Given this list of marker genes Pawr, Nupr1, Foxp3, Atf2, Septin4, Dpt, Rgn, Cebpa, Grem1, Ccr5, Ccl12, Fas, Krit1 (NCBI Gene Id 79264), Eif2ak1, Lilrb4a, Cdc73, Vsig4, Agtr2, B4galt7, Ift52, Fbxo4, Ereg, Trp53inp1, Mmp9, Il12a, Tns2, Cdkn2c, Vsir, Pdcd10, H19, Fgf2, Ski, Axin2, Tgfbr3, Tescl, Jak2, Sod2, Mtss1, F2r, Tyrobp, Tent5b, Trib1, Apc, Plk5, Ceacam1, Tnf, Pde5a, Ptprj, Bche, Fnip1, Rc3h1, Ptges, P3h3, Tgfb1, Trim35, Pdcd1lg2, Shh, Spin4, Raf1, Magi2, Pax6, Hspg2, Rara (NCBI Gene Id 19401), Serpine2, Jun, Hspa1a, Cd300a, Prnp, Apoh, Pak1, S2bpcox16, Kiss1r, Ang, Pten, Tial1, Shoc2, Trem2, Ing4, Dll1, Bnipl, Stk4, Inhba, Mtbp, Zbtb16, Tgif1, Clec4g, Lgals9, Cdk6, Ceacam2, Sh2b3, Runx3, Kcnk2, Msx2, Aqp11, Sox9, Rxra, Smad6, Il2ra, Il1a, Slurp1, Mn1, Adcyap1, Socs1, Tmigd3, Cacnb4, Atg13, Notch1 (NCBI Gene Id 68125), Tbx5, Tafa5, Arg1, Sox11, Wdr6, Cend1, Slfn1, Cblb, Bak1, Stat1, Tert, Cpb2, Cnn1, Myod1, Enpp3, Atf5, Wnt10b, Cdh1, Fezf1, Vgll4, Bax, Ptgs2, Thbs1, Csf1r, Brca2, Bmpr1b, Msx1, Xdh, Adipoq, Tsg101, Dis3l2, Gata2, Insm1, Bap1, Adarb1, Tpm1, Il1rl1, Cldn3, Dnajb2, Trp53, Cops8, Irf6, Rbp4, Rbm10, Cherp, Smad3, Dlk1, Bdnf, Sfrp2, Appl2, Clmn, Med1, H2-T23, Nox4, Ift74, Ctnnb1, Zfp503, Gna12, Glmn, Nr2f2, Myc, Cldn19, Slc16a2, Tgfb2, Apln, Dicer1, Klf9, Gpnmb, Sfrp1, Pmp22, Ripor2, Ascl2, Mir219a-1, Wdr13, Eaf2, Muc16 (mucin 16), Nppc, Sirt6, Esr1, Smarcb1, Timp3, Cdkn2b, Ift88, Kdm2b (lysine (K)-specific demethylase 2B), Il1b, Nodal, Gstp1 (NCBI Gene Id 14870), Pth1r, Synj2bp, Bcl2, Ifi35, Tfap2b, Spry2, Tmem131l, Cpeb1, Gjb6, Fzd5, C1ql4 (NCBI Gene Id 239659), Gli3, Prkg1, Nf2, Itga1, Pkp2, Vash1, Cd24a (NCBI Gene Id 12484), Mstn, Nos1, Ifitm1, Wnt11, Cited2, Srf (NCBI Gene Id 224821), Ndrg4, Nfatc1, Mir1a-2, Pdx1 (NCBI Gene Id 18609), Spry1, Gnrhr, Bmp4, Ift80, Foxa3, Fktn, Lgals3, Tmem127, Csk, Flt1, Gdf5, Sh3bp4 (NCBI Gene Id 98686), Mir219a-2, Ctla4, Bdkrb2, Scin, Lmna, Inppl1, Ngfr, Cd80, Dlc1 (deleted in liver cancer 1), Gper1, Bmp5, Nkx2-9, Kcnn4, Gabbr1, Cd9, Itgb1, Prl, Ppp2r5c, Pde9a, Ephb1, Alox8, Crtam, Gsdme, Niban2, Insl3, Ptgir, Smad2, Prox1, Esr2, Adora3, Tff1, Zbtb49, Mef2c, Aldh1a2, Sox7, Nrk, Phf7, Rapgef1, Ddr1, Pla2g2f, Cdh5, Tlr2, Ang6, Prkar1a, Eppk1, Tsc1, Ndfip1, Med31, Ptprf, Ifi30, Srpx, Krt4 (keratin 4), Btg2 (BTG anti-proliferation factor 2), Smad7, Sparc, Cysltr2, Tmem196, Apoe, Ctcf, Npm1, Fcgr2b, Strn, Comt, Arid2, Rarb, Mmrn2, Hdac2, Adora1, Wnk2, Bcl6, Bmp7, Agtpbp1, Tgfbr2, Fxyd2, Podn, Dusp10, Erbb4, Flt3, Ackr3, Dab2, Il15, Enpp7, Pmaip1, Ager, Fnip2 (NCBI Gene Id 329679), Cd44, Hdac4, Etv4, Erbb2, Atraid, Ptpn2, Rb1, Bcl11b, Cd276, Maged1, St18, Timp2, Npr3, Zfas1, H2-M3, Vax1, Atp5f1a, Hmga1b, Myocd, Cers2, Nf1 (neurofibromin 1), Etv3, Eng, Col4a3, Nfib, Bmpr2, Kank2, Bmyc, Ifng, Ccn6, Tnfrsf14, Tfap2a, Ar, Ovol2, Lzts2, Nmi, Cxcl12, Wt1, Ppargc1a, Myog, Mcc, Foxo4, Ift122 (intraflagellar transport 122), Wnt9a, Tesl1, Ifit3b, Mfn2, Phb2, Slc4a2, Emd, Ifit3, Ahr, Lefty1, Map2k1, Cdkn2a (cyclin dependent kinase inhibitor 2A), Tnfrsf9, Spn, Phox2b, Kmt2a, S1pr2, Gpld1, Lbx1 (ladybird homeobox 1), Akirin1, Ifnb1, Rhoa, Ulk1, H2ac13, Rassf5 (Ras association (RalGDS/AF-6) domain family member 5), Gna13, Ptgdr2, Slc6a4, Stk11, Cav1, Fntb, Rap1gap, Hnf4a, Ift172, Fuz, Pdcd5-ps, Nos3, Isl1, Cask, Kctd11, Dsc1, Lta, Klf13, Rarg, Zeb1, Vip, Tesc, Tes, Smarca2, Nacc2, Tarm1, Ptch1, Ang4, Kiss1, Tnfrsf21, Vtcn1, Taf6, Ang2, Btn2a2, Tpbg, Tspo, Atm, Abcc8, Slfn2, Nfe2, Pdcd4, Smyd2, Men1, Smo, Irgm1, Ccn3, Nppb, Gja1, Ptprv, Mad1l1, Nell1, Sult2b1, Sfn, Pex2 (NCBI Gene Id 52109), Wwc2, Nog, Gnrh1, Marveld3, Sf1, Hpn, Ogn, Twist2, Eif2ak2, Zbtb7b, Gas1, Wfdc1, Il12b, Spint2, Gal, Itgb1bp1, Xcl1, Igfbp5, Sox10, Ilk, Fbxo2, Tbrg1, Itch, Rerg, Ptpru, Avpr2, Ghrl, Casp3, B2m, Vipr2, Robo1, Il24, Tnmd, Tfap4, Slit2, Stat3, Lrp6, Fth1 (NCBI Gene Id 14319), Smad4, Trim32, E2f7, Dlg5, Runx1, Laptm5, Ifna11, Pkn1, Flcn, Rnf41, Nudt6, Tsc2, Skap2, Pttg1, Kat2b, Muc2, Efemp2, Lif, Tax1bp3, Apod, Parp10, Dab2ip, E2f3, Sfrp5, Aimp2, P3h2, Tnfaip3, Tob1, Sulf1, Alox5, Becn1, Ifitm3, Cdkn1a, A4gnt, Hsf1, Acvr1c, Ecrg4, Park7, Eef1e1, Tsc22d1, Trim24, Iapp, Ptprk, Pdcd5, Rgcc, Nlrc3, Nr2e1, Med25, Sirt2, Dach1, Rian, Atoh8 (NCBI Gene Id 71093), Per2, Pparg, Hes1, Fgfr3, Ang5, Il33, Efnb2, Vdr, Intu, Pim2, Nherf1, Hmox1, Ido1, Cib1, Ier3ip1, Fermt1 (fermitin family member 1), Lims2 (LIM and senescent cell antigen like domains 2), Celf1, Idh2, Acvrl1, Pla2g2a, Dusp1, Fap, Suz12, Ovol1, Mapk11, Il10, Wnt5a, Cth, Cnot7, Tinf2, Pds5b, Lyn, Rps6ka2, Twsg1, Ddah1, App, Pdpn, Atg101, Fgfrl1, Klf4, Trpv2, Lst1, Pla2g2d, Gkn3, Ing5, Cer1, B4galt1, Tfdp1, Ripply3, Ambra1, Fgfr2, Gstp2, Gata3, Cnmd, Slfn3, Adora2a, Sftpd, Lims1 (NCBI Gene Id 71899), Dll4 (NCBI Gene Id 54485), Rnf10, Rxfp2, Nupr2, Vsx2, Hras, Plxnb1, Tnn, Zfp777, Igfbp3, Hmga1, Il4, Jarid2 (jumonji and AT-rich interaction domain containing 2), Il4i1, Scgb1a1, Foxj1, Wwc1, Hrg, Marchf7, Rbpj, Ptprz1, Cbfa2t3, Aimp1, Dspp, Cxadr, Fosl1, Agbl4 (NCBI Gene Id 78933), Ptpn14, Hspa1b (heat shock protein 1B), Gtpbp4, Pemt, Agt, Atp5if1, 4930503L19Rik (NCBI Gene Id 74795), Cd86, Slit3, Rb1cc1, Pml, Btg1, Spint1, Minar1, Dnaja3, Drd4, Prdx4, Il20rb, Prkca, Gata1, Lrrc32, Phf14, Cebpb, Ndrg1, Cdkn2d, Nr2e3, Rida, Rgs5, Ace2, Tbx3, Ptpn6, Rest, Pik3r1, Phb1, Hpgds, Rbm38, Ctnnbip1, Npr1, Cd200, Ihh, Gata6, Kifap3, Havcr2, Il6, Zbtb7c, Dhcr24 (NCBI Gene Id 74754), Btk, AY074887 (cDNA sequence AY074887), Adora2b (NCBI Gene Id 632506), Btla, Peli1, Cd109 (CD109 antigen), Morc3, Pla2g5, Ppp2r3d, Tesl2, Adgrg1, Fezf2, Igf1, Cd37, Ptpn1, Chd5, Cyp27b1, Il2, Neurl1a, Ppp1r15a, Cxcr3, Sox4, Ift57, Gdf2, Scrib, Rnf139, Optn, Smad1, Crp, E2f1, Aif1, Tnfrsf13b, Cdh13, Stk3, Kdf1, Sav1, Rapgef2, Ctsl, Dlec1, Sfrp4, Klf11, Cdkn1b, Ptprm, Zc3h12d, Reg1, Xirp1, Ndrg2, Sox2, Pbrm1, Dlg1, Trp73, Drd2, Frzb, Tspan32, Ptgis, Fbln1, Erdr1, Bmp2, Tgfbr1, Cd274, Ptk2b, Ggnbp2, Gdf11, Sdc4, Lilrb4b, Inca1, Ddx20, Zbtb17, Ppard, Fgf10, Ccn5, Myo16, H2-Aa, Tgfb3, Tmigd1, Ntrk1, Nup62, Cyp1b1, Arg2, Cav2, Cdkn1c (cyclin dependent kinase inhibitor 1C), Ptn, Ctnna1, Asph (aspartate-beta-hydroxylase), Snai2, Brip1, Adm, Six5, Nkx3-1, Inpp5d, Wdr77, Gpc3, Serpinf1, Ptgds, here is a description of the gene set: Any process that stops, prevents or reduces the rate or extent of cell proliferation. Mouse Gene Set: GOBP_NEGATIVE_REGULATION_OF_CELL_POPULATION_PROLIFERATION studied in species Mus musculus